Given this list of marker genes LAMP2, LIG1, GAA, STAT6, GTF2A2, KRT19, UBE2N, CRY1, SORL1, LSS, MSMO1, ALOX5, NDUFA4, CCNG2, EYA2, PRDX2, LSM1, ADH5 (alcohol dehydrogenase 5 (class III), chi polypeptide), LGALS3, H2BC5, MARCKS, PRKCA, EPAS1 (endothelial PAS domain protein 1), SEM1 (SEM1 26S proteasome subunit), KYNU, MTMR11, JUP, ABCG1, IDI1, CNBP, TMSB4X, TRAM1, TGFB2, CCN3, ANXA1, MGST1, CTSL, COX7C, TCEA1, ALDH3B2, SAT1 (NCBI Gene Id 6303), ASIC1, AARS1, IFRD1, KCNK1, RYK, PMP22, TAX1BP1, SPINT2, CAMLG, COL4A5, HACD3, PRDX4 (peroxiredoxin 4), VEGFA, STRN3, DRAP1, RNF6, NET1, NME4, BCL7B, HINT1 (histidine triad nucleotide binding protein 1), BMP7, JUND, EPHX2, NEK4, ATF4, GNG10, BTG1, GMFB, PDAP1, SELENOW, here is a description of the gene set: species: Homo sapiens from publication Bae I, Fan S, Meng Q, Rih JK, Kim HJ, Kang HJ, Xu J, Goldberg ID, Jaiswal AK, Rosen EM (PMID 15520196) Mutations of the breast cancer susceptibility gene 1 (BRCA1), a tumor suppressor, confer an increased risk for breast, ovarian, and prostate cancers. To investigate the function of the BRCA1 gene, we performed DNA microarray and confirmatory reverse transcription-PCR analyses to identify BRCA1-regulated gene expression changes. We found that BRCA1 up-regulates the expression of multiple genes involved in the cytoprotective antioxidant response, including glutathione S-transferases, oxidoreductases, and other antioxidant genes. Consistent with these findings, BRCA1 overexpression conferred resistance while BRCA1 deficiency conferred sensitivity to several different oxidizing agents (hydrogen peroxide and paraquat). In addition, in the setting of oxidative stress (due to hydrogen peroxide), BRCA1 shifted the cellular redox balance to a higher ratio of reduced to oxidized glutathione. Finally, BRCA1 stimulated antioxidant response element-driven transcriptional activity and enhanced the activity of the antioxidant response transcription factor nuclear factor erythroid-derived 2 like 2. The ability of BRCA1 to stimulate antioxidant response element-dependent transcription and to protect cells against oxidative stress was attenuated by inhibition of nuclear factor erythroid-derived 2 like 2. These findings suggest a novel function for BRCA1, i.e., to protect cells against oxidative stress. This function would be consistent with the postulated role of BRCA1 as a caretaker gene in preserving genomic integrity. Human Gene Set: BAE_BRCA1_TARGETS_UP Genes concordantly up-regulated in DU-145 and MCF-7 cells (lprostate, breast cancer) upon expression of BRCA1.